The following is a description of a gene set: species: Homo sapiens Any process that modulates the frequency, rate or extent of action potential creation, propagation or termination. This typically occurs via modulation of the activity or expression of voltage-gated ion channels. Human Gene Set: GOBP_REGULATION_OF_ACTION_POTENTIAL, and this is the list of marker genes: SLC4A3, DSP, KCNB1, CAV1, NOS1AP, CACNA1C, FGF12, MTNR1B, CALM1, SLC8A2, CAMK2D, HCN1, CXADR, TAC1, KCNQ3, SLC9A1, DSG2, SUMO1, CASQ2, KCNC2, TRPM4, CD36, CHRNB2, HCN3, RNF207, FGF13, AKAP9, KCNE3, TNF, PKP2 (NCBI Gene Id 93271), KCNK3, NOS1, KCNK16, NPS, ANK2, MIR208A, DSC2, KCNJ2, CALM3, ATP2A2, CAV3, TRPA1, FMR1 (fragile X messenger ribonucleoprotein 1), CACNA2D1, CNR2, GJA5, TACR1, CACNB3, GBA1, HCN4, MIR1-1, MIR133A1, JUP, ADRA1A, SCN5A, TBX18, CTNNA3, RYR2, BIN1, DLG1, KCNK9, FLNA, TMEM161B, RANGRF, MIR328